Given this list of marker genes VAMP2, HMOX1, UBE2J2, SEC61B, STX1A, PRNP, CAMLG, GET3, GET4, ALDH3A2, EMD, VAPA (VAMP associated protein A), SEC61G, OTOF, CYB5A, APP, SGTA, STX5, SERP1, UBL4A (NCBI Gene Id 8266), GET1, BAG6, here is a description of the gene set: Insertion of tail-anchored proteins into the endoplasmic reticulum membrane Human Gene Set: REACTOME_INSERTION_OF_TAIL_ANCHORED_PROTEINS_INTO_THE_ENDOPLASMIC_RETICULUM_MEMBRANE studied in species Homo sapiens